The following is a description of a gene set: species: Homo sapiens from publication Busslinger GA, Weusten BLA, Bogte A, Begthel H, Brosens LAA, Clevers H (PMID 33691112) Human Gene Set: BUSSLINGER_GASTRIC_CHIEF_CELLS, and this is the list of marker genes: FTL, GPRC5C, RPLP1, TMED6, SOX4, FMOD, MT2A, CST3, PABPC4, CDKN1C, IL33, NR2F2, GPER1, ELL2, SSR4 (NCBI Gene Id 6748), GLUL, IGFBP2, P4HB, SEC62, APLP1, CXCL17, ELAPOR1, ITLN1, ITIH5, PRDX4, UGT2B15, SLC12A2, PLIN5, FTH1, PGC, MT1X, EEF2, LEPR, TMEM97, IER2, LINC00261, PDIA2, ENAH, CA9, PGA5, TSC22D1, FNDC3B, DCXR, AZGP1, MECOM, MT1F, NEDD4L, JUN, IRX2, LIPF, XYLT2, TMT1A, MT1G, CHIA, HMGCS2, XBP1